Given this list of marker genes Ces1d, Nme1, Vav1, Ggt7, Tpmt, Akr1c20 (aldo-keto reductase family 1, member C20), Ugt2b36, Cyp3a57, Ugt3a1, Ugt2a3, Slco1a4, Nudt15, Slc22a1, Ugt1a8, Akr1c6, Gmps, Ugt2a2, Glyatl3, Ggt5, Bche, Gstm6, Akr1c13, Alb, Ugt2a1, Hsd11b2, Cyp3a41b, Impdh2, Serpina6, Cyp3a13, Ugt1a7c, Abcc4 (NCBI Gene Id 239273), Ugt2b1, Slc29a3, Ggt1, Guk1, Akr1c14, Slc29a2, Nat1 (NCBI Gene Id 17960), Cyp3a25, Cyp3a41a, Ces2h, Cyp2c66, Nat3, Pon1, Abcg2, Ugt1a9, Pnp2, Bsg, Nme2, Acsm5, Ugt1a5, Gstt1, Cyp2e1, Ugt2b37, Gsta13, Cyp2d22, Nt5c2, Cyp2c65, Pon3, Akr1c21, Cyp3a16, Gsta1 (NCBI Gene Id 14857), Cyp3a11, Slc22a2, Ggt6, Gsta2, Abcc2, Ada, Abcc3, Ugt2b38, Ugt2b35, Akr1c18, Adal, Xdh, Acsm4, Cyp3a44 (NCBI Gene Id 337924), Nat2, Ugt1a6a (NCBI Gene Id 94284), Gstp1, Pnp, Acsm2, Gsta3, Slc22a3, Ugt1a1, here is a description of the gene set: This event has been computationally inferred from an event that has been demonstrated in another species.<p>The inference is based on the homology mapping from PANTHER. Briefly, reactions for which all involved PhysicalEntities (in input, output and catalyst) have a mapped orthologue/paralogue (for complexes at least 75% of components must have a mapping) are inferred to the other species. electronically inferred by orthology from the curated human pathway Reactome Pathway: Drug ADME studied in species Mus musculus